Given this list of marker genes CTDNEP1, KAT5, SCARB1, GPLD1, MIR29B1, SLC27A1, SREBF1, PLIN5, NR1H3, LDLR, NR1H2, MFSD2A, DGAT2, CNEP1R1, here is a description of the gene set: Human Gene Set: GOBP_POSITIVE_REGULATION_OF_TRIGLYCERIDE_BIOSYNTHETIC_PROCESS Any process that increases the rate, frequency, or extent of triglyceride biosynthesis. Triglyceride biosynthesis is the collection of chemical reactions and pathways resulting in the formation of triglyceride, any triester of glycerol. species: Homo sapiens